The following is a description of a gene set: Mouse Gene Set: GOMF_LIPOPROTEIN_PARTICLE_RECEPTOR_ACTIVITY Combining with a lipoprotein particle and delivering the lipoprotein particle into the cell via endocytosis. A lipoprotein particle, also known as a lipoprotein, is a clathrate complex consisting of a lipid enwrapped in a protein host without covalent binding in such a way that the complex has a hydrophilic outer surface consisting of all the protein and the polar ends of any phospholipids. species: Mus musculus, and this is the list of marker genes: Cd36, Ldlr, Stab1, Lrp10, Vldlr, Cxcl16, Lrp1b, Lrp6, Apobr, Lsr, Ildr1, Olr1, Lrp8, Stab2, Atp5f1b, Scarb1